The following is a description of a gene set: Human Gene Set: REACTOME_PIWI_INTERACTING_RNA_PIRNA_BIOGENESIS PIWI-interacting RNA (piRNA) biogenesis studied in species Homo sapiens, and this is the list of marker genes: MOV10L1, TDRKH, PLD6, FKBP6, TDRD6, HENMT1 (HEN methyltransferase 1), POLR2I (NCBI Gene Id 5438), POLR2E, TDRD1, POLR2G, POLR2L, MAEL, POLR2A, POLR2J, POLR2F, POLR2C, POLR2K, ASZ1, POLR2H, PIWIL2, HSP90AA1, PIWIL4, POLR2B, POLR2D, DDX4, MYBL1, TDRD12, TDRD9, PIWIL1